The following is a description of a gene set: studied in species Homo sapiens Interferon cluster genes up-regulated in skin tumors treated with imiquimod. Human Gene Set: UROSEVIC_RESPONSE_TO_IMIQUIMOD BACKGROUND: Imiquimod, an immune response modifier that is used topically to treat different types of skin cancer, induces the production of proinflammatory cytokines that stimulate an antitumor immune response. We assessed characteristics of the imiquimod-induced immune activation in epithelial and lymphoproliferative neoplasias of human skin. We focused on plasmacytoid predendritic cells (PDCs), the primary producer of interferon alpha (IFN-alpha) after imiquimod activation in vitro. METHODS: We used Affymetrix oligonucleotide arrays to compare gene expression profiles from tumors from 16 patients, 10 with superficial basal cell carcinomas (sBCCs), five with cutaneous T-cell lymphomas (CTCLs), and one with Bowen's disease, before and after topical imiquimod treatment. We used quantitative immunohistochemistry with PDC-specific antibodies against BDCA-2 and CD123 to characterize the PDC population before and after imiquimod treatment in these specimens. Activation status of PDCs from four sBCC patients was assessed by intracellular IFN-alpha staining and flow cytometry. RESULTS: Expression of various IFN-alpha-inducible genes (e.g., CIG5, G1P2, OASL, IFIT1, STAT1, IFI35, OAS1, ISG20, MxA, and IRF7), the so-called IFN-alpha signature, was increased similarly in both sBCC and CTCL lesions after imiquimod treatment. PDCs were recruited and activated in both lesion types, and they produced IFN-alpha after imiquimod treatment in vivo (mean percentage of PDCs producing IFN-alpha = 14.5%, 95% confidence interval = 4.9% to 24%; range = 3.3%-27%, n = 4 lesions). Imiquimod induced similar immune activation patterns in all three diseases, and these patterns were associated with the number of PDCs recruited to the treatment site. Two imiquimod-treated sBCC patients who did not mount an inflammatory response to imiquimod and whose lesions lacked the IFN-alpha signature after treatment had fewer PDCs in treated lesions compared with other treated patients with such a response. CONCLUSIONS: Imiquimod induces immune activation patterns that relate to the number of the PDCs recruited to the treatment site, thus supporting the role of PDC in responsiveness to imiquimod in humans. from publication Urosevic M, Dummer R, Conrad C, Beyeler M, Laine E, Burg G, Gilliet M (PMID 16077073), and this is the list of marker genes: ISG20 (interferon stimulated exonuclease gene 20), IDO1, MX1, IFI35, IFI6, PLAAT4, OAS2, SECTM1, BRCA1, IL6, OASL, STAT1, CXCL11, TRAFD1, CCL8, ISG15, IFITM1, MICB, IRF7